The following is a description of a gene set: The transcriptional activity of the RUNX1:CBFB complex is regulated by interaction with co-factors and posttranslational modifications of RUNX1. Protein serine/threonine kinase HIPK2 can phosphorylate RUNX1 and affect transcriptional activity of the RUNX1:CBFB complex during hematopoiesis. Some CBFB mutations found in leukemia interfere with HIPK2-mediated phosphorylation of RUNX1. HIPK2 can simultaneously phosphorylate RUNX1 and EP300 (p300) bound to the RUNX1:CBFB1 complex.<br>The RUNX1:CBFB complex can associate with the polycomb repressor complex 1 (PRC1). PRC1 complexes are found at many RUNX1 target promoters and can act either as co-activators or co-repressors in the transactivation of RUNX1 targets.<br>RUNX1 recruits the SWI/SNF chromatin remodeling complex to many RUNX1 target promoters by directly interacting with several SWI/SNF subunits.<br>Other co-factors of the RUNX1:CBFB complex are annotated in the context of transcriptional regulation of specific genes. Reactome Pathway: RUNX1 interacts with co-factors whose precise effect on RUNX1 targets is not known species: Homo sapiens part of: Transcriptional regulation by RUNX1, and this is the list of marker genes: SMARCC1, PHC1, SMARCD3 (NCBI Gene Id 6604), SMARCA4, HIPK2, SCMH1, SMARCC2, CBX6, PBRM1, CBX8, RNF2, RYBP, BMI1 (BMI1 proto-oncogene, polycomb ring finger), SMARCB1, RING1, SMARCE1, CSNK2A2, RUNX1, SMARCD1, SMARCA2, ARID2, PHC3, EP300 (E1A binding protein p300), ARID1A, ACTL6B, PHC2, CBX4, AUTS2, YAF2, ACTL6A, PCGF5, CBX2, ARID1B, CSNK2B, CBFB, SMARCD2, CSNK2A1 (casein kinase 2 alpha 1)